The following is a description of a gene set: Human Gene Set: REACTOME_DEFECTIVE_FACTOR_IX_CAUSES_HEMOPHILIA_B species: Homo sapiens Defective factor IX causes hemophilia B, and this is the list of marker genes: GP1BB, GP1BA, GP9, F11, F10, GP5 (NCBI Gene Id 2814), GGCX, F8, F9